The following is a description of a gene set: Genes predicted to be targets of miRBase v22 microRNA mmu_miR_1197_5p in miRDB v6.0 with MirTarget v4 prediction scores > 80 (high confidence targets). species: Mus musculus Mouse Gene Set: MIR_1197_5P from publication Chen Y, Wang X (PMID 31504780), and this is the list of marker genes: Cnot6, Rad21, Zfp157, L3hypdh, Dcn, Zfp367, Fam174a, Cpne4, Mff, Pltp, Nudt4, Ankrd44, Rnf111, Chrm3, Gpatch2, Tmem33, Cadps2, Mrpl53, Kmt2a, Onecut2, Mical2, Kcnq5, Ccdc87, Fbxl5